Given this list of marker genes CNIH2, VTI1A, SCAP, YIF1B, YIF1A, LMAN1L, ECPAS, CD74, SAR1B, USO1, HLA-E, TMED5, CIDEB, SAR1A, TMED2, ERGIC2, KLHL12, ERGIC3, HLA-C, TMED10 (NCBI Gene Id 10972), FOLR1, TMED4, SEC23IP, HLA-DQA1, TGFA, SLC30A5, VTI1B, TMED6, CRYZL2P-SEC16B, SERPINA1, TMED3, SEC22B, HLA-DRB5, HLA-DQB1 (NCBI Gene Id 7924), HLA-DRB4, SEC24C, TMED7, VANGL2, DDHD2, B2M, LMAN2, CTSZ, PEF1, SEC24D, YIPF6, HLA-DPA1 (NCBI Gene Id 7935), SEC24B, SREBF1, GOLGA2 (NCBI Gene Id 2801), STX5, SEC16A, IER3IP1, TMED1, PCSK9, F8, HLA-A, HLA-DRA, VMA21 (vacuolar ATPase assembly factor VMA21), HLA-DQA2, CNIH1, F5, COL7A1, ERGIC1, CNIH4, HLA-DRB1, STX17, GOSR2, GRIA1, SEC23B, CTSC, SEC23A, SEC31A, SREBF2, MCFD2, SEC13, SEC16B, TMED9, AREG, SEC31B, SEC24A, HLA-H, LMAN1, SURF4 (NCBI Gene Id 6836), HLA-G, HLA-F, YIPF5, HLA-DRB3, CNIH3, LMAN2L, HLA-B, PDCD6, TEX261, HLA-DPB1, HLA-DQB2, CD59, here is a description of the gene set: Human Gene Set: GOCC_COPII_COATED_ER_TO_GOLGI_TRANSPORT_VESICLE A vesicle with a coat formed of the COPII coat complex proteins. The COPII coat complex is formed by the Sec23p/Sec24p and the Sec13p/Sec31p heterodimers. COPII-associated vesicles transport proteins from the rough endoplasmic reticulum to the Golgi apparatus (anterograde transport). studied in species Homo sapiens